The following is a description of a gene set: from publication Jeffrey KL, Brummer T, Rolph MS, Liu SM, Callejas NA, Grumont RJ, Gillieron C, Mackay F, Grey S, Camps M, Rommel C, Gerondakis SD, Mackay CR (PMID 16474395) Human Gene Set: GSE3982_NEUTROPHIL_VS_BCELL_DN In the present study we used Affymetrix oligonucleotide microarrays to produce gene transcription profiles for the major leukocyte types in humans. This comprehensive dataset enabled us to not only establish which genes were expressed in each leukocyte type, but also which genes were expressed in each subset after activation. The used of a comprehensive dataset of gene profiles from all the major human leukocyte subsets enabled a novel and powerful means for identification of genes associated with single leukocyte subsets, or different immune paradigms. studied in species Homo sapiens Genes down-regulated in comparison of neutrophils versus B cells., and this is the list of marker genes: KPNA2, PFDN4, RPL10L, RPL8, PRPF19, STARD5, N4BP2L1, BET1, RANBP1, CDKL3, IARS1, PEX10, NOLC1, HDHD5, DHFR, DPAGT1, HLA-DMB, STAMBPL1, CD86 (CD86 molecule), C2CD2, NAA40 (N-alpha-acetyltransferase 40, NatD catalytic subunit), CPSF4, DTWD1, NPRL3, FGA, RPS16, GOLGA3 (NCBI Gene Id 2802), LPIN1, CLIC4, LCK, GEMIN6, PXMP2, TRMT61B, MOCS2, PDE4DIP, AIMP2, GGA2, EEF1G, KYAT1, DNAJC15, STOML2, ABCF2, SOX4, UCN (urocortin), KNOP1, IL27RA, AVEN (apoptosis and caspase activation inhibitor), RPUSD2, LAGE3, COX7C, TMX2, HINT1, WRAP73, ZNF395, IRF4, FGFR4, RPL13A, VIPAS39, LRIG1, PMS2P5, KHDRBS1, ZBTB14, GTPBP4, SEH1L, PPIA, FBN1, GALT, RAN, PSMF1, PSMG2, TRAF5, PNP, PHKB, ERAP1, AKR7A2, UBE3C, MGA, SMIM10L1, RPS4X, BCAT2, FAM162A (family with sequence similarity 162 member A), HEXA, PRDM14, PTER, ACP5, RARS1, POLR3E, RPN2, RFX5, G3BP2, LARP4, ARL2BP, CTBP1, HDAC9, GOLPH3, MMACHC, CTNNBL1, SS18, DMAC2L, RPL9, BAG2, CUTA, PKD1P1, YBX1, ANAPC5, REXO2, MYC, MRPL17, RPL31, AK2, UAP1, UBR7, CEP112, PTPRK, EIF2B5, AKR1B1, TARS1, TOP3B, NFX1, NFU1, ADI1, TUBG1, ZC3H14 (NCBI Gene Id 79882), TMEM131, CD72, RPS18, RALGPS2, R3HDM1, RPL13, FOLR1, UQCRC2, S1PR1, CAMK2N1, CYB5A, RAB29, MGST3, ZNF74, VGLL4, RCN2, ZBTB3, ESYT1, PARP2, PNOC, GNB5 (G protein subunit beta 5), RUVBL2, SDAD1, CRYZ (crystallin zeta), RUBCN, PCNT, BIRC3, MBD3, UTP18, HLA-DMA, DFFB, SYNGR3 (NCBI Gene Id 9143), SSB, MRPL40, DIPK1A, DCK, ANXA2P2, RNMT, RRM1, RPL32, NDUFB8, MRPL35, ATP8B3, DBR1, HERC4, ADCK2, RPS19, HDAC1, RPS23, ZNF211, YARS1, RTCB, AKAP1, RPAP1, APPL1, PIP5K1B, ATP13A1, STAP1, EIF3F, POLR2G (RNA polymerase II subunit G), BFAR, SUPT3H, AAMP, RUSC1, ARHGEF10, DPP3, RPS27, TNFRSF13B, MAP3K4, RPL35A, RABGAP1, PCBP4, CPSF6, TMSB10, FAM136A